The following is a description of a gene set: from publication Peltier DC, Simms A, Farmer JR, Miller DJ (PMID 20483728) Human Gene Set: GSE16450_IMMATURE_VS_MATURE_NEURON_CELL_LINE_6H_IFNA_STIM_UP Genes up-regulated in neuron cell line treated with interferon alpha for 6h: immature versus mature. studied in species Homo sapiens Human neuronal differentiation alters responsiveness to innate immune stimuli and virus infections. We used microarrays to examine the transcriptional responses of the human BE(2)-C neuroblastoma cell line to retinoic acid-induced differentiation and type I IFN stimulation., and this is the list of marker genes: RARG, SH3RF2, WNT3, FAM83G, SLCO1B3, ADAR, PARP4, HID1, AHNAK, ENTPD6, SORL1, MSL1, QPRT, LIMS4, ITGA1, POU2AF1, ZNF157, PADI1, TOX2, KCTD12, WIPF2, OPN1SW, HIGD1B, ZBTB4, LMNA, TMTC2, SMAD6, SAA1, SELP, PCSK5, AMN, PRR5L, KLHL18, IL33, ATP10D, OTOS, RAPGEF2, PPP2R5B, DPP4, IFIT1B, SOX8, TFEC, FBXW4, RIMS3, ZNF628, ADM, LGALS3, EVL, MBTD1, GPR171, UNC45B, PRCP, UPK3B, HOXD1, KDM6B, HCG4, FIGLA, LDHAL6B, MARCHF3, TM4SF20, CDH16, PPTC7, NRN1, OLFML2A, ADGRD1, GPLD1, TNRC18, FMO5, ADGRG3, ELL3, GSR, UPK1B, IL25, GHR (NCBI Gene Id 2690), DNAJB8, LAG3, SMG1, GXYLT2 (glucoside xylosyltransferase 2), LRRC17, CBLB, KLC2, OTUD1, IL1R2, FSCN3, ZFYVE28, SLC22A7, HLA-DQA1, RDH5, SPHKAP, UTF1, GP2, AP3B2, SNX29, MAP3K6, PATJ, PTCHD4, CCDC39, CDKN1C, ASAP1, DACH2, HAL, RNF19A (ring finger protein 19A, RBR E3 ubiquitin protein ligase), KIFC3, ZNF236, UGT2B15, LRP6 (LDL receptor related protein 6), IMPACT, GSG1L, CYB5RL, SNPH, ANO8, UCN2, HOXB9, AFF2, RIPOR2, CCDC17, CD84, ZBTB2, TMEM31, WNT9A, RAB27B, KCNE5, LINC00301, MSI2, MCTP2, STIM1, CILK1, KCNA3, FOXO3, ERBB2, EFNA1, COMMD9, PLEKHO1, KMT2D, BTLA, IL13, XYLT2, XKRX, EEF1A2, TTLL7, PTH2R, LRRN4CL, HOXC10, AVPR1B, LETM2, CCR9, PRKCZ, SH3BGRL2, MFSD2B, DTX4, SMAD9, IGF1R, CHAD, SERPINB1, LRP1B, PACSIN1, TLL1, HCAR1, FRK, GABRR2, LKAAEAR1, RP1L1, IL17RD, FAM167A, LYPD5, KMO, ANP32A, SCT (secretin), GPR84, HSD17B11, MAP3K1, TNRC6C, NNMT, SLC27A5, MAP3K3, HIVEP2, MYOZ3, SOX7, DBNDD2 (dysbindin domain containing 2), CXXC5, PFKFB4, BAZ2B, SYT1, EVI2B, ZP2, TTC17 (NCBI Gene Id 55761), IFITM5, ZRANB1, NCOA1, SYNE2, IGFBP7, MEF2D, KRT36, PHOX2A, FOXJ2, TMEM17, FRAT2, RTN1, CXCL10